The following is a description of a gene set: from publication Weng Y, DiRusso CC, Reilly AA, Black PN, Ding X (PMID 16006652) Genes down-regulated in liver from transgenic mice with reduced expression of POR in all tissues. species: Mus musculus Mouse Gene Set: WENG_POR_TARGETS_GLOBAL_DN NADPH-cytochrome P450 reductase (CPR) is an essential component for the function of many enzymes, including microsomal cytochrome P450 (P450) monooxygenases and heme oxygenases. In liver-Cpr-null (with liver-specific Cpr deletion) and Cpr-low (with reduced CPR expression in all organs examined) mouse models, a reduced serum cholesterol level and an induction of hepatic P450s were observed, whereas hepatomegaly and fatty liver were only observed in the liver-Cpr-null model. Our goal was to identify hepatic gene expression changes related to these phenotypes. Cpr-lox mice (with a floxed Cpr gene and normal CPR expression) were used as the control. Through microarray analysis, we identified many genes that were differentially expressed among the three groups of mice. We also recognized the 12 gene ontology terms that contained the most significantly changed gene expression in at least one of the two mouse models. We further uncovered potential mechanisms, such as an increased activation of constitutive androstane receptor and a decreased activation of peroxisomal proliferator-activated receptor-alpha by precursors of cholesterol biosynthesis, that underlie common changes (e.g. induction of multiple P450s and suppression of genes for fatty acid metabolism) in response to CPR loss in the two mouse models. Additionally, we observed model-specific gene expression changes, such as the induction of a fatty-acid translocase (Cd36 antigen) and the suppression of carnitine O-palmitoyltransferase 1 (Cpt1a) and acyl-CoA synthetase long chain family member 1 (Acsl1), that are potentially responsible for the severe hepatic lipidosis and an altered fatty acid profile observed in liver-Cpr-null mice., and this is the list of marker genes: Fgl1, Rad51b, Hsdl2, Grn, Atf5, Acot1, Mgll, Apoa4, Cyp2c39, Hsph1, Elovl5, Cyp4a31, Egr1, Vnn1, Ehhadh, Retsat, Hsd17b10, Mtap (methylthioadenosine phosphorylase), Fabp2, Naa80, Hsd17b11, Rab30, Slc22a5, Acot2, Cyp7b1